Given this list of marker genes FOXE3, FBXW4, FAM111A, PITX2, DLX5, SDHA, KIF1B, BRCA2, POU6F2, PAX6, SDHC, LDHD, DLST, CHN1, MAX, FOXC1, VHL, SDHB, TP63, GPC3 (glypican 3), EPS15L1, H19, WT1, ITPR1, NF1, RET, TRIP13, TRIM28, TRIM44, BTRC, MAFB, DLX6, ELP4, PORCN, SDHD, SLC25A11, DIS3L2, FH, SALL4, TMEM127, MDH2, SDHAF2, SEM1, WNT10B, REST, here is a description of the gene set: species: Homo sapiens Aniridia Human Gene Set: HP_ANIRIDIA Abnormality of the iris characterized by, typically bilateral, complete or partial iris hypoplasia. The phenotype ranges from mild defects of anterior iris stroma only to almost complete absence of the iris.